The following is a description of a gene set: The synthesis of transfer RNA (tRNA) from a DNA template. studied in species Homo sapiens Human Gene Set: GOBP_TRNA_TRANSCRIPTION, and this is the list of marker genes: POLR3D, GTF3C4, BRF1, GTF3C3, GTF3C2, POLR3A, POLR2E, GTF3C6, POLR2L, POLR2F, GTF3C1, GTF3C5